The following is a description of a gene set: Any process that stops, prevents or reduces the frequency, rate or extent of ubiquitin protein ligase activity. studied in species Homo sapiens Human Gene Set: GOBP_NEGATIVE_REGULATION_OF_UBIQUITIN_PROTEIN_LIGASE_ACTIVITY, and this is the list of marker genes: FBXO5, CDKN2A, MAD2L2, RPL23, RPL11, RPS7, RPL5, USP44, MAD2L1